Given this list of marker genes Lgals3bp (lectin, galactoside-binding, soluble, 3 binding protein), Cdc42bpg, Epm2aip1, Zfp345, Cdk2ap1, Usp15, Asic2, Unc5b, Zmynd19, Zfp976, Nxph2, Mr1, Spef2, Sc5d, Cdc40, Sarnp, Ankrd40, Pcsk1n, Meioc, Akr1c14, Ap3m1 (adaptor-related protein complex 3, mu 1 subunit), Cux1, Slc11a2, Nmnat2, Hs3st3b1, Fndc3b, Atp5mc3, Dpm2, Trpc6, Colec10, AI182371, Hyal1, Ncbp3, EU599041, Setdb1, Specc1, Slc7a14, Spry2, Ralgapb, Mc2r, Gm2042, Otof, Ehd2, Zfp936, Ube2d2a, Cpeb3, Ppm1b, Ankib1, Foxd2, Zfp120, Slc25a32, Chrna6, Pxdc1, Edil3, Lrp3, Nrf1, Zfp975, Zfp810, Cdc7, Mtcl1, Ift56, Tsc22d1, Gabrb3, Cpeb1 (cytoplasmic polyadenylation element binding protein 1), Zfp825, Pdzk1ip1, Ppp4r3b, Septin10, Ccr9, Fmnl3, Mecp2, Gabra2, Sstr2 (NCBI Gene Id 20606), Mid1, Nckap1l, Mbnl1, Clstn1, Bambi, Jakmip3, Enah, here is a description of the gene set: from publication Chen Y, Wang X (PMID 31504780) studied in species Mus musculus Genes predicted to be targets of miRBase v22 microRNA mmu_miR_7221_3p in miRDB v6.0 with MirTarget v4 prediction scores > 80 (high confidence targets). Mouse Gene Set: MIR_7221_3P